The following is a description of a gene set: species: Mus musculus Mouse Gene Set: GOBP_OOGENESIS The complete process of formation and maturation of an ovum or female gamete from a primordial female germ cell. Examples of this process are found in Mus musculus and Drosophila melanogaster., and this is the list of marker genes: Ptx3, Zar1, Dcaf13, Tut4, Mettl3, Dnmt3a, Fmn2, Inhbb (NCBI Gene Id 16324), Zfx, H3f3b (NCBI Gene Id 78941), Ythdc2, Pde3a, Mei4, Gpr149, Ehmt2, Insl3, Npm2, Rxfp2, Dmrt1, Ccnb1, Grb14, Oosp2, Marf1, Ybx2, Bcas2, Cntrl, 4930447C04Rik, Lgr5, Pabpc1l, Sirt2, Adrm1, Brca2, Ednra, Taf4b, Tdrd6, Ercc1, Fbxo5, Diaph2, Meiosin, Kmt2b, Paqr8, Dnmt3b, Plcb1, Piwil2 (NCBI Gene Id 57746), Rbm46, Ythdf2, Spo11, Rps6, Ptk2b, Kat8, Mei1, Rps6ka2, Spdya, Bmpr1b, Bnc1, Wee2, Zscan21, Dnmt3l, Shb, Tdrd1, Oog1, Paqr7 (progestin and adipoQ receptor family member VII), Tdrd5, Washc5, Mdk, Stra8, Nppc, Figla, Trip13, Rec114, Hormad1, Tdrd7, Nanos3, Dazl, Tut7, Paqr5, Zp3, Mcmdc2, Nobox, Terb2, Zglp1, Tm9sf5, Kash5, Sohlh2, Ptn, Igf1, Aspm (NCBI Gene Id 12316), Pde5a (phosphodiesterase 5A, cGMP-specific), Ddx20, Cyp51, Zfp830, Dmc1, Sebox, Ezhip, Tnfaip6, Washc1, Rec8, Mlh1, Atm, Hfm1, Meioc, Tdrkh, Ihh, Bcl2, Kmt2d, Hexb (hexosaminidase B), Zar1l, Iho1, Majin, Foxo3 (forkhead box O3), Ythdc1, Cdc25b, Ereg, H3f3a, Edn1, Akt1, Nanos2, Ctnnb1, Pld6, Gdf9, Lsm14b, Src, Sohlh1, Npr2, Mos, Nanos1, Aurka, Wdr77, Amh, Wnt4, Ppp2r1a